The following is a description of a gene set: The change in morphology and behavior of a granulocyte resulting from exposure to a cytokine, chemokine, cellular ligand, or soluble factor. species: Homo sapiens Human Gene Set: GOBP_GRANULOCYTE_ACTIVATION, and this is the list of marker genes: ITGAM, CD300A, PLA2G2A, LILRA2 (leukocyte immunoglobulin like receptor A2), ITGB2, SPI1, PRAM1, FCER1G, IL18, TRAF3IP2, SCNN1B, CLEC12A, DNASE1L3, CCL3, STXBP2, FCER1A, CD177, GKN2, KMT2E, CCL5, IL15, MYD88, CXCR2, FCGR2B, SYK, IL18RAP, IL16, PREX1, CCR2, FCAR, DNASE1, SRC, ANXA3, CXCL8, CXCL6, MIR125A, VAMP8, ENPP3, PRG3, CAMP, STX4, VAMP7, CTSG, TNF, PRKCD, TYROBP, KARS1, VAMP2, PTPN6, PLPP6, STXBP3, BCR, IGHE, ANXA1, F2RL1, PTPN11, GRN